The following is a description of a gene set: The process that involves the secretion of or response to endocrine hormones. An endocrine hormone is a hormone released into the circulatory system. Mouse Gene Set: GOBP_ENDOCRINE_PROCESS studied in species Mus musculus, and this is the list of marker genes: Wnk4, Apln, Corin, Ren1, Kcnk9, Rab11fip1, Tac1, Agtr1b, Lif, Ace3, Prep, Retn, Mfn2, Crhr2, Tmf1, Ace, Or51e2, Mrgprd, Cyba, Crh, Crhr1, Pex5l, Rab8b, Tbx3, Oprk1, Edn3, Nos3, Gja1, Pparg (peroxisome proliferator activated receptor gamma), Ptpn11, Bmp6, Agtr1a, C1qtnf3, Klk1b26, Kiss1, Drd3, Spp1, Cga (NCBI Gene Id 12640), Avpr1a, Agtr2, Rab11fip5, Npvf, Ucn, Comt, Inhbb, Ace2, Foxl2, Fzd4, Hcar2, Inhba, Gata3, Cpa3, Gal, Crhbp, Aqp1, Trpv6, Fgfr1, Pomc, Mme, Avpr1b, Drd5, Selenom, Cry2 (NCBI Gene Id 99248), Agt, Foxd1, Tacr1, Nr3c2, Mcpt4, Ndst2, Rasl10b, Niban2 (NCBI Gene Id 227737), Smad4, Ednrb, Prcp, C1qtnf1, Vdr, Kdm5b, Ghrl, F2r, Rhoa, Cry1, Enpep, Acvr2a, Nrg1, Oprm1, Hsd11b2, Mas1, Nkx2-1, Gja5 (gap junction protein, alpha 5), Kcnn4, Gnas, Serpinf2, G6pdx, Galr1, Oxtr, Nox1, F2rl1, Cyp11b2, Rab11fip3, Cyp2j5, Gdf9, Cyp19a1, Atp6ap2, Runx1, Nkx3-1, Tacr2, Avpr2, Cyp27b1, Ucn2, Anpep, Inha, Edn2, Fgfr4, Sucnr1, Ecrg4, Tspo, Dab2, Kcnq1, Lep, Edn1, Ece1, Rps6ka2, Il1b